Given this list of marker genes PSEN1, DCTN1, SQSTM1, ATP10A, GRN, MAPT, VCP, SNRPN, RNU4-2, CRLS1, TMEM106B, UBE3A, TREM2 (NCBI Gene Id 54209), PRNP, CHMP2B, SHANK3, here is a description of the gene set: Hyperorality is a condition characterized by an excessive preoccupation with oral sensations and behaviors, such as chewing, sucking, biting, swallowing, and excessive mouthing of objects. species: Homo sapiens Hyperorality Human Gene Set: HP_HYPERORALITY